The following is a description of a gene set: Mouse Gene Set: MIR_3618_3P Genes predicted to be targets of miRBase v22 microRNA mmu_miR_3618_3p in miRDB v6.0 with MirTarget v4 prediction scores > 80 (high confidence targets). studied in species Mus musculus from publication Chen Y, Wang X (PMID 31504780), and this is the list of marker genes: Txndc12, Ptpn2, Asah1, Vezf1, Zfp120, Fhip1b, Cd2ap, Rps6ka6, Ntng1, Scn3a, Mbd5, Rnf103, Tshz1, Lin9, Ankib1, Wrn, Tfb1m, Prpf4b, Naa30, Arf1, Rp1, Azi2, Baz2a, Wt1, Rnf19a, Rictor, Pcdh8 (NCBI Gene Id 73497), Gpatch8, H2-M10.1 (NCBI Gene Id 14985), Sema6a, Scoc, Otor, 1700019D03Rik, Fut9, Casr, Kctd1, Dusp10, Ppfibp1, Hcn1, Cdan1, Csta1, Cks2, Abca5, Rab8b, Nipbl, Clock, Zfp281, Gm14296, Dcaf1, Sirt1, Per2, Nap1l5, Calb1, Api5, Zfp36l2, Setd2, Elf1, Arfip1, Nfs1, Kmt2e, Arid1b, Mctp1, Vamp5, Stk39, Ikzf2, Cyth3, Ciart, Zfp521, Skic8, Pbx3, Otc, Commd8, Vsnl1, Ing5, Fbrsl1, Lrrn1 (NCBI Gene Id 72710), Taf3, P2ry10, Cbfa2t2, Mysm1, Casq1, Tm2d3, Tmem135, Mb21d2, Htt, Sema7a, Noct, Eif4e, Cfdp1, Slc35e2, Wnt5a, Pspc1, Tmeff1, Map3k2, Adipoq, Col25a1, Csrnp3, Ednra, Zfp385b, Magee1, Pcmtd1, Asxl3, Uba2, Foxp1, Krtap20-2, Abcg5, E2f3 (E2F transcription factor 3), Hells, Fign, Rbbp6, Phactr4, Rc3h2, Brinp1, Zfp1008, Fkbp7, Tbc1d9, Iqch, Pomt1, Galc (NCBI Gene Id 78595), Ugt2b37, Crisp4, Ubqln2, Prss59, Pxdc1, Abhd13, Slc25a16, Frs2, Pik3c2a, Mcmbp, Tbc1d23, Tubb2b, Lyve1, Pum1, Kmt2a, Ing3, Oprm1, Ski, Pcdh10, Pds5b, Atp6ap2, Pik3r3, St8sia6, Hmgcs1, Rab33b, Kbtbd11, Fmr1, Cry1, Scai, Fbxl3, Gspt1, Ythdc2, Ptpn21, Esr1, Ptprb, Flrt3, Dmrt2, Atad1, Mycbp2, Ube2k, Zfp280c, Prdm16, Ppp2r3a (protein phosphatase 2, regulatory subunit B'', alpha), Golim4, Arl8b, Sel1l, Tbk1, Micos10, Zfp97, Nr1d2, Polr2k, Zfp975, Zfp935, Ubxn2a, Tmem123, Rab18, Kmt2c, Ulk2, Kitl, Slitrk1, Wdr20, Pdcl, Rapgef6, Mitf, Ahr, Zfp131, Ccdc121rt1, Fnip1, Gsx2, Gtf2e1 (general transcription factor II E, polypeptide 1 (alpha subunit)), Dusp6, Lrba, Mcl1 (NCBI Gene Id 99928), Ube2f (ubiquitin-conjugating enzyme E2F (putative)), Chmp5, Naaladl2, Cnep1r1, Rpsa, Kctd12, Tshz3, Reep1, Ensa (NCBI Gene Id 99644), Erlec1, Lox, Sgip1, Sgk1 (serum/glucocorticoid regulated kinase 1), Zfp976, Scaf11, Gtf2h5, Lmo7, Klf3, Enox1, Dnajc6, Mat2b, Atp1b1, Gpr22, Gnai1, Csmd1, Ptbp3, Hrnr, Psmc6, Slc38a1, Klf9, Npepps, Kcnj13, Zfand5, Grm3, Htr2c (5-hydroxytryptamine (serotonin) receptor 2C), Tmem68, Cdc14a, Bcar3, Wtap, Ttc9, Jakmip2, Fndc3a, Ifrd1, Akirin2, Prickle1, Azin1, Slc35f3, Cul2, Ugt2b5, Ids, Plxna3, Csmd2, Gria4, Gin1, Syde2, Ddx54, Pf4, Sec24a, Pank3, Rap1b, Usp15, Socs4, Eef1e1, Phlpp1, Thsd7a, Bclaf1, Slc46a2, Tead1, Poli, Necab1, Psmg2, Egr1, Dmtf1, Bach2 (NCBI Gene Id 319905), Ccl28, Cpeb4, Larp4, Nsun6, Pi4k2b (NCBI Gene Id 74082), Hmbs, Edn2, Wdr44, Tox3, Kdm4c, Sestd1, Rnf11, Hectd2, Pclo, Sptssa, Ccdc88a, Hnrnph3, Plcxd2, Usp33, Ecm2, Tubgcp5 (tubulin, gamma complex component 5), Tmem41b, Phip, Lclat1, Chl1, Kcne3, Golph3, Bcl2l11, Ttc39b, Fubp1, Slc4a5, Acsl6, Rbl1, Atad5, Rfx3, Pdzrn4, Pde6d, Zfp608, Tmeff2, Ssr1, Rock2, Gria2, Rheb, Odf2l, Dab2ip, Gpsm2, Stim2, Uba6, Ccng2, Plppr5, Fam120c, Elavl4, Rps6ka3, Cd164, Tmx3, Nfatc2ip, Zbtb41, Rabgap1l, Twist2, Carf, Lin52, Mettl14, Pik3ca, Ptf1a, Tlcd4, Mapk8, Ppargc1a, Nampt, Atp8b1, Ubp1, Tmco3, Nin, Reck, Bri3, Htr1f, Psme3, Eif1, Zfp960, Efr3a, Gapt, Rorb, Chac2, Cavin2, Phf8, Prkacb, Ahctf1 (NCBI Gene Id 98619), Galnt13, Epb41l4a, Fndc3b, 2210418O10Rik, Nf1, Ap1s2, Cdc42bpb, Slc39a12, Atg10, Btbd3, Chd1, Prkci, Rnf207, Zfp936, Cilk1, Or5m3b, Gtf2b, Serinc3 (NCBI Gene Id 98830), Nexmif, Lrrk2 (NCBI Gene Id 79409), Wfdc21, Arhgap42, Mbnl2, Lpl, Lgalsl, Relch, Kras, Cacybp, Trim71, Sacm1l, Megf9, Slc4a7, Ciao1, Cyfip2, Ap1s3, Rnf182, Mblac2, Senp8, Diaph2, Ppm1b, Appl1, Grpel1, Zfp1009, Sh3gl3, Actl11, Xpot, Zfp781b (NCBI Gene Id 331188), Fbxo3